The following is a description of a gene set: Human neuronal differentiation alters responsiveness to innate immune stimuli and virus infections. We used microarrays to examine the transcriptional responses of the human BE(2)-C neuroblastoma cell line to retinoic acid-induced differentiation and type I IFN stimulation. Genes up-regulated in immature neuron cell line: control versus interferon alpha (6h). Human Gene Set: GSE16450_CTRL_VS_IFNA_6H_STIM_IMMATURE_NEURON_CELL_LINE_UP species: Homo sapiens from publication Peltier DC, Simms A, Farmer JR, Miller DJ (PMID 20483728), and this is the list of marker genes: TTC3, UNC45B, BCL6 (BCL6 transcription repressor), BMP2K, IARS1, FANCD2OS, KIF26A, TMEM218, RGS20, ZNF182, RAPGEF2, PITPNC1, ERCC5, C2orf49, ETV3, ZC3H12C, DCLRE1C, CDK12, IL1R2, SLC30A4, RNF114, CP, OSBPL8 (oxysterol binding protein like 8), ZNF518A, RBPMS2, RALGAPA2, SEL1L3 (NCBI Gene Id 23231), GPR171, MGAT4A, DPP4, ZBED5, TTLL7, TLR3, CIMIP2A, NODAL, DAW1, ARHGEF6, SPPL2A, PARP3, CREB1, APC (APC regulator of WNT signaling pathway), BHLHE22, TPH2, ROBO2, AFF3, VCAM1, STX11, SDE2, TINAG, ATP8A2, CYB561, WSB2, ATP7A, CHST15, ZFC3H1, TMPRSS3, CTNNA3, YPEL4, SLAMF1 (signaling lymphocytic activation molecule family member 1), CBLB, UMOD, IMPACT, LEFTY2, ADH4, USP38, MIB1, CD96, NDST2, DOP1A, ANXA1, DSP, STAB1, YAF2, SHC4, PPFIBP1, RPRD1A, TSPAN6, PSAPL1, ACAP2, SCO1, MFHAS1, GLCE, EXOC6B, GBP2, CYP4X1, RNF19A, DSC2, PPP2R1B, CD79B, MARCHF5, HAGH, UTRN, INPP5B, SLC39A14, GPR84, NOTCH2, CD226, SLC45A4, ETV6, RNF170, C3, FOXP3, SACS, GBP6, SLC27A2, LDHB, SMIM13, TIMM29 (translocase of inner mitochondrial membrane 29), NT5DC1, AVPR1A, ZBTB40, SAG, DLEU7, FLCN, MRPL9 (mitochondrial ribosomal protein L9), ANKRD46, POT1, TAFA4, HBA2, NGLY1, TGFBRAP1, ANO6, BFAR, PARD6B, UBR1, ZRSR2, MFF, EXTL2, TMEM74, THNSL2, ZNF189, ZBTB44 (NCBI Gene Id 29068), GPRASP2, C3orf62 (chromosome 3 open reading frame 62), FNDC10, CATSPERZ, ELMOD2, INKA1, SEMA5A, LITAF, EPS15L1, IFIH1, ZNF628, FCGR3A, GRHL1, RREB1, C1orf216, BTLA, NCOA1, CD302, MOG, CCNG1, CD160, TRHDE (NCBI Gene Id 29953), FOXN3, NOTCH1, SYT5 (NCBI Gene Id 6861), PCCA, APLNR, ATG10, GRAMD1B, SLC25A36, TMEM237, IL1RAP, HFE, LRRC75A, LACTB, RABGAP1L, TLE4, DUSP16, PLEK, FCRL1, TTC9C, EPS15, DCLK1, SCN9A, JAK2, GNA13, CDK6 (NCBI Gene Id 1021), AFF1, RB1, CUBN, ANKRD7, WARS2, KLHL20, REG1A, SYNE4, ZNF236, PPM1E, IFIT1B, MRPS6 (NCBI Gene Id 64968), FNIP1, CRTAM, ATF7IP2, PDZRN3, NPC2, IL22, EXOC2, ZUP1, MAGEA11